Given this list of marker genes Cyp3a41a, Cyp3a44, Cyp3a11, Cyp3a41b, Cyp3a16, here is a description of the gene set: Mouse Gene Set: GOBP_ALKALOID_CATABOLIC_PROCESS The chemical reactions and pathways resulting in the breakdown of alkaloids, nitrogen containing natural products not otherwise classified as peptides, nonprotein amino acids, amines, cyanogenic glycosides, glucosinolates, cofactors, phytohormones or primary metabolites (such as purine or pyrimidine bases). studied in species Mus musculus